The following is a description of a gene set: Mouse Gene Set: GOBP_REGULATION_OF_DNA_TEMPLATED_TRANSCRIPTION_INITIATION Any process that modulates the frequency, rate or extent of DNA-templated transcription initiation. studied in species Mus musculus, and this is the list of marker genes: Med9, Setx, Morc1, Med10, Med16, Xpa, Gtf2a1, Taf9, Med6, Taf3, Mitf, Med13, Med28, Nkx2-5, Rrn3, Med23, Med15, Taf11, Taf5, Ctnnbip1 (NCBI Gene Id 93799), Taf6, Hmgb1, Med25, Taf7, Med19, Twist1, Cand1, Taf10, Hnf1b, Taf8, Taf13, Ahr, Thra, Med1, Hey2, Srf, Ikzf1, Med27, Ercc6, Med17, Gtf2a2, Znhit1, Nfkbia, Med26, Med14, Kat8, Dhx36, Med4 (mediator complex subunit 4), Nfkb1, Med18, Taf4b, Hnf1a, Fosl1, Med21, Jun, Med20, Zfp473, Pwwp2a, Med30, Med11, Taf1, Med12, Taf2, Myc, Cebpa, Trp53, Foxo1, Taf4, Zfp451, Med22, Bmyc, Med8, Med29, Ercc1, Pou5f1, Psmc6, Sub1, Tbp, Med7, Creb1, Med24, Taf12, Wnt10b, Bclaf1, Med31, Paxip1